Given this list of marker genes Arl5a, Phox2b, Exosc2, Gm8883, a, Gapvd1, Sorcs2, Rtl5, Vcp, Fuz, Akr1a1, Gm11827, Gm15222, Cacng8, Capn10, Spin2c, Slc7a2, Atpaf1, Rhbdd2, F930017D23Rik, Tamm41, Meioc, Cars1, Pgf, Rplp2, Epdr1, Ube2c, E130114P18Rik, Ttf1, Eftud2, Ppp4r1, Neu1, Hsp90ab1, Slc18a3, Cav1, Gm42799, Atg13, Zfp661, Crybg2, Hnrnpk, Gm12936, Lrfn5 (NCBI Gene Id 328106), Arhgef7, Cenpe, Gm23483, Gm28836, Gm13570, Tm4sf5, Pgpep1l, Gm12654, Kank3, Olfr1401-ps1, Ezh1, Or5p52, Tmem53, Trim43a, Gm4353, Slc22a8 (solute carrier family 22 (organic anion transporter), member 8), 1110059E24Rik, 9330136K24Rik, Spata16, 1700129L04Rik, 4933434E20Rik, Hspa8, Ncaph, Slc25a51, Cfap73, Ankdd1a, Ppp1r10, Tnfsf15, Imp4, Vpreb1a, Lrriq4, Idh3b, Mcf2l, Thrap3, Src, Utp25, Atp6v0a4, Pick1, B3gnt2, Gm14491, Prcc, Usp1, Ighv5-4, Gm13740, Fam216a, Bcl7b, Zfp748, Mis18bp1, Zfp809, Fbxl22, Acad11, Supt7l, Kcnk6, Znrf1, Zmat1, Sulf1, Psma3, Slc38a11, Gm4349, Gm8213 (predicted pseudogene 8213), Tspan17 (tetraspanin 17), 1700022A21Rik, Sgce, Scd4, Map2k1, Uba52, Pold3, Acyp1, Flvcr1, Gm9955, Gnl3, Tet1, Stradb, Celf1, Top3b, Scn3b, Ino80, Usb1, Rnf121, Csmd2, Nemp2, Hint1 (NCBI Gene Id 15254), Gzmm, Nbeal2, Agfg2, Reps1, Ly6g, Enah, Mfge8, Ica1l, Usp19, Hbq1b, Pcmtd2, Fgfr1op2, Rex1bd, Ndufs5 (NADH:ubiquinone oxidoreductase core subunit S5), Phlpp2, Cngb3, 4833439L19Rik, Ern2, Zfp426, Gm29718, Pde9a, Hapln1, Gm19557, A430018G15Rik, Gm16185, Scpep1, Gm24400 (predicted gene, 24400), Ash2l, Gm27811, Gm22027, Slc30a2, Dhtkd1, C130036L24Rik, Slc2a9, Slc25a36, Psmb3, Plcb2, Clk2, Rassf1, Sipa1, Plcxd2, Ino80d, Surf6, Gm11625, Klhl18, Adamts6, Trpm1, Capza1, Cpsf4 (NCBI Gene Id 97240), Birc6, Dcakd, Cdh13, Palld, Anp32e, Hoxa11os, Arl2bp, Kcnh8, Triobp, Gtf2i, Scn3a, Gm9887, Trap1, Ift172, Ptges3, En1, Bin2, Gm17806 (predicted gene, 17806), Traj1, Bnip1 (BCL2/adenovirus E1B interacting protein 1), Faddos, Ntpcr, Rdm1, Cpne1, Magohb, Pcmt1, Acsl3, 1110002J07Rik, Ubxn1, Cp, Gm22675, Adgrl1, Gpr35, Nhsl2, Mrpl14, Ttc13, 1700023G09Rik, Redic1, Oaz2, Ctbp2, 5430401F13Rik, Hoxa7, Gm6526, Cyb5r3, Nhlrc2 (NCBI Gene Id 66866), Tmem39a, Il17rd, Cers6, Tfap4, Slx4, Gm23645, Mfsd11, Hcls1, Tmeff2, Dpy30, Mir7668, Treml4, Gm26670, Mepce, Map2k6, Or10ad1, Bcas2, Tomm34, Ralbp1 (ralA binding protein 1), Cct3, Nckap5, Tmem42, P2rx7, Cyp2b23, Cln3, Tet3, Gm7891, Hhip, Plekhg1, Snord52, Ints5, Slc38a8, Ppfia1, Taf6l, Lmo7, Ccdc47, Mir6956, Pcdh19, Chchd10, Gm6783, Tcirg1, Nsd3, Krtap20-2, Qtrt2, Ipo11, Scn9a (sodium channel, voltage-gated, type IX, alpha), Mamdc4, Rad51c, Pigb, Gm22497, Prpf38b, Apof, Thpo, Plekha6, 2010016I18Rik, Gm23341, Fcgr2b, Gm13529, Gm8398, Lgmn, Mir6924, Arhgap45, Il27ra, St14, Rab43, Gm2990, Iho1, Itpa, Arhgef2, Lrp11, 2810407A14Rik, Gm26122, Vmn1r193, Tbc1d9b, Prkrip1, Gltpd2, Tbl2, Azin2, Timm17a, Rtl6, Traj7, Ttf2, Aars1, Rps12-ps26, Pccb, Foxl2os, Ift140, Sntb2, Wdr75, Gm8186, Mrpl20, Slfn5, Lcn12, Cblc, Usp21, Arl15, Map4, Zfp85os (zinc finger protein 85, opposite strand), Pparg (peroxisome proliferator activated receptor gamma), Cnot1, Pex19, Inpp5k, Ptk6, Zfp64, Mir3618, Zfp319, Prrg3, Mdk, H3f3c, Ccr4, Dclre1a, Tdrd9, Ahctf1, Fgfr2, Gm9506, Prss8, Tmem61, Ninj2, Teshl, Stpg3, Sox1 (NCBI Gene Id 20664), Ttll9, Acot11, Tor1a, Anapc10, H1f11-ps, Ric3, Tsn, Park7, Mbtps2, Plec, Amigo1, Ddb2, Bcar3, Usp14, Rabl6, Cnbd2, Hsd3b7, Yju2 (NCBI Gene Id 72886), Zbtb1, Chrna9, Shroom3, Gpr68, Stn1, Tor1aip2, Sirt7, Arhgap15, Gm24403, Rpsa-ps4 (NCBI Gene Id 432548), Hspa4, Gm26684 (predicted gene, 26684), Mlxip, Adgrl3, Mir1306, H2-Q6, D030068K23Rik, Slc35a3, Prss54, Gm8641, Glo1-ps, Amz1, Pde7b, Pkd2l1, Kif2c, Rabep2, Rnf146, 4930528J11Rik, Gm23382, Lipo3, Gm25369, Tmco2, Dnah7b, Gm10062, Sec31a, Frat1 (NCBI Gene Id 14296), Haus5, Vmn2r-ps55, Olig3, Gse1, Spcs1 (NCBI Gene Id 69019), Matn3, 1700008O03Rik, C630004M23Rik, Gm2710, Mir152, Aspscr1, Sirt4, Sun1, Tle2, Gm7993, Mthfd2l, Siah1b, Gm13022, Tnfrsf1a, Gm24296, Aff1, Csdc2, Gm12924 (NCBI Gene Id 102633376), Tigd4, Gm28453, Tap2, Bmp8b, Fnbp4, Abhd5, 9530082P21Rik (RIKEN cDNA 9530082P21 gene), Luc7l3, Gm16276, Prrt1b, Inpp5b, Kifbp, Mlkl, Gm15806, Golga5, Fbrsl1, Ccdc115, Gm24665 (NCBI Gene Id 115486155), Rbck1, Zfp512b, Rab11a, Anapc15, Cldn22, Tenm2, Cirbp, Rell1, Atp8b3, Rhot1, Elane, Gm14098, Slc25a38, 1700074H08Rik (NCBI Gene Id 73480), Nr1h4, Doc2g, Mir376c (microRNA 376c), 1700003F12Rik, Nadsyn1, Cnot3, Gm5473, Dock2, Gm23817, Wdfy3, Zhx2, Cdc42ep1, Carhsp1, Atf6, Gm13213, Dsc1, Fam186b, Cd9 (NCBI Gene Id 12527), Gm37116, Ubiad1, Myo5b (myosin VB), Pi4ka, Prr5l, Kcnj16, Clcn7, Nova1 (NCBI Gene Id 664883), Igf1, Axl, Thap1, 1700052I22Rik, Ube2k, Fam76a, Abraxas1, Gm13196, Gm25916, Prr14, Myo1g, Recql, Rab27a, Slc25a53 (solute carrier family 25, member 53), Gm10309, Hormad2, Gm25402, Aatf, Bcas1, Mxra8, Ppp1cb, Stx6, Gm23390, Tcea2, 4933408N05Rik, Snhg12, Ebf2, Nrg4, Mir326, Gm29707, Catsper2, Zfp609, Ccdc14, Mkrn2os, Mroh1, Pde4d, Foxp1, Gm37885, Gm15610, Elp3, Zfp27, Plekha3, Mir770, Gm24204, Gadd45gip1, Gm4918, Nfasc (NCBI Gene Id 269116), Ascl4, Bmal2 (NCBI Gene Id 77587), Gm4915, Saraf, Tmem242, 4930568G15Rik, Idh2, Mthfsd, Gm12125, Ilf3, Wdr5, Gcn1, Mast1, Glra2, Gm7097, Fndc7, Ccdc191, Syne4, Cds2, Dgcr8 (DGCR8, microprocessor complex subunit), Trp53cor1, Tpd52l2, Gm12803, Elk4, Rps12-ps7, Rida, Itpr2, Ulk4, Zmiz2 (NCBI Gene Id 97766), Smok3a, Smpd2, Rasal2, Timm17b, Tmed2, Nusap1, Adamts19, Uhrf1, Nup58, Cnga3, Nktr, Mir376a, Ehbp1, Rpl18, Tfrc, Ccnb2-ps, Gm6491, Gtf2h3, Tor1aip1, Tram1, Caml, Sult2b1, Gm4914, Syt3 (synaptotagmin III), Rpsa-ps9, C1galt1, Trim67, Taok3, Uba2, Zeb1os1, Pdxdc1, Gm5766, Gm13677, Srpk1, Mad2l1, Gm4961, Atrnl1, Samd1, Pan3, Ralgapb (Ral GTPase activating protein, beta subunit (non-catalytic)), Apobec1, Tcof1, Misp3 (NCBI Gene Id 70134), Mir7035, Gm6366, P4ha2, Eif4a-ps4, Cyp4a28-ps, Elp5, BC050972, H2af-ps2, Mir3085, Nup160, S1pr4, Dpp6, Wdr81, Gm18859, Bmal1, Gm14175, Snf8, Rpl38, Gm19705, Gpkow, Gm15651, Usp3, Ckap2, Niban2, Atp5f1d, Bnip3l, Ino80dos, Phf20, Abcf3, Ocrl, Nif3l1, Sass6, Rcor2, Uvrag, Gm25482, Tubgcp3, Dnajc17, Hcn3, Gm34248, Prss40, Thap6, Jak1, Il4, Sema4g, Mta2, Nsf, Plekha5, Tango2, Gpr157, Ralgps1, Pnpla3, Wdr95, Mir300, Gstp3 (NCBI Gene Id 225884), Itgb5, Sinhcaf, Sox15, Dpf1, Gm12608, Zfp354c, Rora, Socs2, Gm16261, Drd1, Ints13, Pdzd9, Tfdp1, Shoc1, Gm25184, Acat1, Smpd1, Gm36527, Pigm (NCBI Gene Id 98637), Ndufa12-ps, Mir1199, Tbx22, Gabra2, Gm11444, Snhg7os, Psmd11, Triap1, Limch1, Lag3, Gm17227, Lyzl6, Nectin3, Babam2, Ing4, Dars2, Recql5, Creb3l3, 4930517L18Rik, Gm15039, Prickle4, Rph3a, Gin1, Gm15903, Trcg1, Insl6, Psph, Or6n1, Gm17271, Gm10531, Gpr62, Akap1 (A kinase anchor protein 1), Nfe2, Gm24905, Gm20544, Gm12740, Gm12156, Kat2b, Mxd3, Rasa4, Gm26510 (predicted gene, 26510), Map4k4, Cngb1, 2900092N22Rik, Chchd2-ps, Dync1h1, Lactb2, Zfp212, Stag3, Trpm3, Gm5049, Adamts1, Lrrc75aos1, Nek2, Gm3830, Ccer2, Fry, Gm8093, Irf8, Uckl1, Gm9726, Fam83c, Ppp1r3f, Mir654, Ppp2r5c, Ccdc170, Obox4-ps6, Mpi, Pgap2, Gm5258, Mllt11, Ncor1, Herpud1, Zfp106, Cep95, Ube2i (NCBI Gene Id 76085), Acadvl, Uts2r, Creb3l2, Speg, Tsga13, Adck2, Gm18254, Gm22972, Cep63, Ncoa4, Sapcd2, Sema4d, Rps6-ps3, Gm11292 (NCBI Gene Id 193453), Smad7, Nrbp1, Rpl29, Dnm2, Psmb6, Gm26049, Gm14622, Epha10, Magea3, Morrbid (myeloid RNA regulator of BCL2L11 induced cell death), Nrgn, Fat2, Tet2, Scube3, Cdr2l, A2ml1, Safb, Gsr, Snord17, Gm12333, Rhbdl2, Cit, Vmn2r-ps58, Fyb1, Mir7238, Mir7664, Erg, Setd1a, Manba, Gm29999, Gm16580, Gm2474, Bnc1 (basonuclin zinc finger protein 1), Tcf7, Nos1, Txndc2, Tulp3, Paupar, Akr7a5, Gm2431, 9430015G10Rik, Zfp961, Gm6985, Alms1, Tsc22d4, Mtfr1, Tenm4, Zan, Frmd5, Ikbke, Ralgps2, Rnf214, Gpn3, Fbxo21, Sfmbt2, Hnrnpr, Bola2, Pde4c, Snta1, Ech1, Rsf1, Mir376b, Stat3, Zfp395, Lhfpl4, Dera, Gpr107, Gm7094, Atp5mj, Dkkl1, Ablim1, Gm24873, Yars1, Gfm1, Nadk2, Lmo2, Gm3786, Gm19637, Awat2, Eya3, Agps, Trim34a, Gm24068, Copz2, Pask, Slain1, Mov10l1, Tnpo3, Gm12109, 1700001O22Rik, Gm24461, Ccdc65, Csf1r, Fhip2b, Camk1g, Gcnt7, Lpin2, Dnajb2, Esyt2, Klk8, Cygb, Sardh, Gm24631, Smtn, Mdn1, Tmem202, Gm10729, Rbm5, Gm2830, Dhx9, Bloc1s6, Ndufs4, Eif2d, Degs2, Arhgef19, Gm9599, Atrip, Vamp1 (NCBI Gene Id 78668), Zdhhc15, Gm6872, Gm15032, Trp53rka, Ptbp1, 5730435O14Rik, C230071H17Rik, Bace1, Zfp708 (zinc finger protein 708), Acmsd, Cib1, Ctnna3, Ltk, Gm11619, Sdf2, Nudt5, Tex14 (NCBI Gene Id 97747), Mrps10, Gm9097, A630072M18Rik, Fuca1, Nipbl, Togaram2, Gm25930, Abcg3, Cenpk (centromere protein K), Psmd2, Zhx3, Hrob, Pou2f2, Wfs1, Eps15, Flad1, Emc8, Nsun5, Paxip1, Ppil2, Gm7069, Fanca, Nrxn3, Cnppd1, Cep170, Slc12a3, Mylpf, Tmem266, S100pbp, Hoxa11, Sp2, Mkln1, Nek9, Fcna, Gm10653, Mettl13, Pisd-ps1, Gm5251, Kcnt2, Mal, Zbtb25, Atp2b4, Pzp, Srpk2, Med1, Ppfibp2, Nap1l2, Zbtb43, 2210417A02Rik (NCBI Gene Id 70138), Smok3b, Tshz1, Gm23706, Exosc1, Gm28651, Gm11771, Grk5, Rnf4, Timm13, Raly, Snora17, Sag, Ndel1, D030056L22Rik, Pdk1, Itgal, Unc13d, Tatdn2, H2-M5, Krtap20-22, Ephb6, Mcm2, Rpgrip1, Ankrd10, Serpine2, Gm24878, Gm14987, Gm6285, Fsip2l, Brap, Slco1c1, Shmt1, Psme4, Xab2 (NCBI Gene Id 67439), Gm13110, Pigl, Dlg4, Mvd, Capns1, Defb38, Mcfd2, Tcp11, Sptan1, Tnfaip3, Med23, Gm15821, Hspe1-ps5, Gpc2, Thoc2l, Platr22, Lztr1, Jakmip1, Nr4a3, Dnaaf9, Zfr, Pdia3, B3gat1, Kazald1, Cnnm3, Mpped1, Gm4847, Gm25608, Gm16084, Terf2 (telomeric repeat binding factor 2), Dhcr7, Pcdh1, Fam114a2, G3bp2 (NCBI Gene Id 319444), Nbr1, Fam81a, Zfp142, Tsnax, Abhd16a, Gm24797, Srsf1, Spink10, Elac2, Ctxnd2, Gabbr2, Slc2a3, Kif5b, Dnajc11, Papss2, Nr3c1, Gfer, 1110038B12Rik (NCBI Gene Id 75391), Agpat2, Ywhag, Lrriq1, Ercc6, Runx1, Gm43772, Nts, Sumf2, Xpnpep2 (NCBI Gene Id 338497, X-prolyl aminopeptidase (aminopeptidase P) 2, membrane-bound), Zfp532, Top2a, Tekt5, here is a description of the gene set: from publication Yevshin I, Sharipov R, Kolmykov S, Kondrakhin Y, Kolpakov F (PMID 30445619) Mouse Gene Set: GM14406_TARGET_GENES studied in species Mus musculus